Given this list of marker genes TNFSF11, P2RX4, EDN1, PLA2G10, PLA2G4A, SLC22A8, NOS2, SLC22A2, SLCO2A1, SLCO2B1, PTGS2, OXT, SLC22A6, ABCC4, SLCO3A1, SLC22A1, PTGES, MIF, SLCO4A1, LEP, P2RX7, TNFRSF11A, IL1B, PLA2G3, SLCO1B1, ACSL4, SLC22A11, SLC22A7, here is a description of the gene set: Human Gene Set: GOBP_PROSTAGLANDIN_TRANSPORT The directed movement of prostaglandins into, out of or within a cell, or between cells, by means of some agent such as a transporter or pore. species: Homo sapiens